Given this list of marker genes Adm, Ramp1, Ramp2, Calcb, Ramp3, Calca, Iapp, Calcr, Calcrl, Adm2, here is a description of the gene set: species: Mus musculus Calcitonin-like ligand receptors Mouse Gene Set: REACTOME_CALCITONIN_LIKE_LIGAND_RECEPTORS